Given this list of marker genes Gm40332, Car5a, Rfx2, Kmt5b, Srp9, Myorg, Mroh6, Scg3, Omg, Pax5, Septin2, Gm28874 (predicted gene 28874), Snord35a, Raf1, Mapk8ip2, Mlxip, Clcn7, 1700088E04Rik, Stk25, Alkbh1, Krt86, Mir300, Gm16126, Srsf1, Gprin1, Gm24435, Sfswap, Pgk1, Gm26175, Kcnb1, Bola2, Sfmbt1, 1700022A21Rik, Mir376a, Il17rd, Pola1, Mir654, Rph3a, Hnrnph2, Cep95, Fbll1, Marchf4, Cinp, Ccdc40, Dnajc11, Ilf2, Gnl3, Gm24296, 1110018N20Rik, Cops6, Mir7b, Utp25, Neurod4, Mapk1ip1, Agfg2, Cacng2, Gla, AY512931, Gm17815, Cpne9, 4930405O22Rik, Fbxo21, C130036L24Rik, Sinhcaf, Tent4b, Fbxo27, Nup160, Mrpl14, Uhrf2, Mir376b, Gm9887, Scn3b, Gm12125, Dock7, Cxcr3, Cap2, Scrt1, Tafa3, 4921517D22Rik, Cyb5r4, Tex35, Gm14264, Ciao1, Yif1a, Trmt1, Gm13816, Tex14, Irak2 (interleukin-1 receptor-associated kinase 2), Polrmt, Sema4d, Glt6d1, Cnpy4, Taf6, Cacna2d4, Zfp811, Tjp2 (NCBI Gene Id 226034), Glra1, Barhl1, Gm15927, Spmip1, Dpep3, Chd1, Cep170, Nf2, Ptp4a1, Sod2, here is a description of the gene set: from publication Yevshin I, Sharipov R, Kolmykov S, Kondrakhin Y, Kolpakov F (PMID 30445619) Mouse Gene Set: ZFP617_TARGET_GENES species: Mus musculus